Given this list of marker genes PRKAA1, CCR7, ADCY6, CCL19, CCL21, TNFSF4 (TNF superfamily member 4), ACACA, PTGER2, GNB1, AKAP8, PRKAA2, SFRP1, GNAS, P2RY6, PTGER4, GNG2, PRKCE, AKT1, P2RY4 (NCBI Gene Id 5030), here is a description of the gene set: Any process that results in a change in state or activity of a cell (in terms of movement, secretion, enzyme production, gene expression, etc.) as a result of a prostagladin E stimulus. species: Homo sapiens Human Gene Set: GOBP_CELLULAR_RESPONSE_TO_PROSTAGLANDIN_E_STIMULUS